Given this list of marker genes POLR1B, CNP (2',3'-cyclic nucleotide 3' phosphodiesterase), VPS16, C19orf12, GCH1, CEP85L, GNAS, ATP13A2, SCP2, CASR, COL6A1, REEP1, FTL, SUPT16H, PARK7, PRKN, ATP5MC3, TRPM3, SLC19A3, AARS1, TUBB2B, GNA11, MAPT, COL25A1, NDUFA6, NEK9, POLR1C, NAA10, STX16, ALG9, TBC1D24, COLEC11, ITGA7, HSPG2, PLP1, TIMM8A, PHOX2A, TBP, CACNA1A, SPG11, DDC, TGFB2, FGFR2, KCNA1, NGLY1, CHN1, HEXB, HPCA, FLI1, ZNF142, B3GALT6, HINT1, SIGMAR1, TWIST1, THAP1, CHD8, PHLDB1, STARD7, KCNN2, NKX6-2, KIF1C, PNKD, CP, TAF1, TOR1A, POLR1D, VPS13A, IMPDH2, CIZ1, MECR, LTBP2, PRRT2, MYOC, FOXP2, PRKRA, ATN1, KCTD17, TEK, KIF21A, PRKAR1B, GRIK2, KCNC3, MAFB, TSPOAP1, TRPV4, FGFR3 (NCBI Gene Id 55546), VPS13D, TUBB4A, TMEM151A, TUBB3, PLA2G6, SPTLC1, FUS, GDAP2, TGM6, SYNGAP1, SPTBN1, COASY, SALL4, ARX, TUBA1A, GNAL, COL6A2 (collagen type VI alpha 2 chain), COL12A1, ALDH18A1, ATP1A3, ANO3, POLR1A, ALS2 (alsin Rho guanine nucleotide exchange factor ALS2), SLC39A14, VPS11, DRD5, COL6A3, NAXE, SGCE, TH, UBAP2L, COX20 (NCBI Gene Id 116228), SLC6A3, ROBO3 (NCBI Gene Id 64221), VAC14, PRKCG, PANK2, NR4A2, MYF5 (NCBI Gene Id 4617), CYP1B1, SOX10, RNF170, PCGF2, AOPEP, CDK10, TACSTD2, PRDX3, TCOF1, ACTA1, KMT2B, CPLX1, DRD2, HK1, here is a description of the gene set: Focal dystonia species: Homo sapiens A type of dystonia that is localized to a specific part of the body. Human Gene Set: HP_FOCAL_DYSTONIA